Given this list of marker genes Car9, Car13, Car7, Car6, Car4, Car12, Car5a, here is a description of the gene set: electronically inferred by orthology from the curated human pathway Reactome Pathway: Reversible hydration of carbon dioxide part of: Metabolism This event has been computationally inferred from an event that has been demonstrated in another species.<p>The inference is based on the homology mapping from PANTHER. Briefly, reactions for which all involved PhysicalEntities (in input, output and catalyst) have a mapped orthologue/paralogue (for complexes at least 75% of components must have a mapping) are inferred to the other species. studied in species Mus musculus